Given this list of marker genes Cav2, Cav1, AU040320, Pikfyve, Eps15, Tpcn1, Jpt2, Siglec1, Rnasek, Tpcn2, here is a description of the gene set: Any endocytosis that is involved in the uptake of a virus into a host cell. species: Mus musculus Mouse Gene Set: GOBP_ENDOCYTOSIS_INVOLVED_IN_VIRAL_ENTRY_INTO_HOST_CELL